The following is a description of a gene set: species: Mus musculus The series of events in which a lipopolysaccharide stimulus is received by a cell and converted into a molecular signal. Lipopolysaccharide is a major component of the cell wall of gram-negative bacteria. Mouse Gene Set: GOBP_DETECTION_OF_LIPOPOLYSACCHARIDE, and this is the list of marker genes: Nr4a1, Casp4, Ly96, Tlr4, Scarb1, Trem2